The following is a description of a gene set: Reactome Pathway: RUNX3 Regulates Immune Response and Cell Migration species: Homo sapiens part of: Transcriptional regulation by RUNX3 RUNX3-mediated transcription regulates development of immune system cells. RUNX3 is necessary for the development of innate lymphoid cells (ILCs) of ILC1 and ILC3 lineages, which reside in the mucosa and are involved in response to external pathogens. RUNX3 exerts its role in the development of ILC1 and ILC3 lineages by stimulating expression of the RORC (RORgamma) gene, encoding nuclear retinoid-related orphan receptor-gamma.<br>RUNX3 regulates transcription of integrin genes ITGAL (CD11a) and ITGA4 (CD49d), involved in transendothelial migration of leukocytes during immune and inflammatory responses as well as co-stimulation of T cells. The RUNX3 splicing isoform p33 lacks the Runt domain and is unable to transactivate integrin genes. The p33 isoform is induced during maturation of monocyte-derived dendritic cells (MDDC), leading to reduced expression of genes involved in inflammatory responses, such as IL8 (interleukin-8).<br>RUNX3 positively regulates transcription of the SPP1 (osteopontin) gene, which contributes to invasiveness of pancreatic cancer cells., and this is the list of marker genes: SPP1, ITGAL, CBFB, RUNX3, ITGA4 (integrin subunit alpha 4), RORC